Given this list of marker genes P2RX7, UBE2N, NLRP1, N, UBE2V1, PSTPIP1, RIPK2, TRAF6, HMOX1, TAB2, BCL2L1, MEFV, fljB, PANX1, UBB, MAP2K6, UBC, CASP9, BIRC3, TAB3, TXN (NCBI Gene Id 7295), RELA, CHUK, CASP4, RPS27A, hly, AIM2, MAPK11, CARD9, TXNIP, IRAK2, MAP3K7, NFKB1, ITCH, prgJ, NFKB2, NLRC4, CASP8, TAB1, MAPK14, NOD2 (nucleotide binding oligomerization domain containing 2), AAMP, HSP90AB1, NOD1, CASP1, IRAK1, IKBKG, TNFAIP3, NLRP3, IKBKB, APP, BCL2, SUGT1, PYCARD, fliC, MAPK13, BIRC2, UBA52, MAPK12, CASP2, CYLD, here is a description of the gene set: part of: Innate Immune System The innate immune system is the first line of defense against invading microorganisms, a broad specificity response characterized by the recruitment and activation of phagocytes and the release of anti-bacterial peptides. The receptors involved recognize conserved molecules present in microbes called pathogen-associated molecular patterns (PAMPs), and/or molecules that are produced as a result of tissue injury, the damage associated molecular pattern molecules (DAMPs). PAMPs are essential to the pathogen and therefore unlikely to vary. Examples are lipopolysaccharide (LPS), peptidoglycans (PGNs) and viral RNA. DAMPs include intracellular proteins, such as heat-shock proteins and extracellular matrix proteins released by tissue injury, such as hyaluronan fragments. Non-protein DAMPs include ATP, uric acid, heparin sulfate and dsDNA. The receptors for these factors are referred to collectively as pathogen- or pattern-recognition receptors (PRRs). The best studied of these are the membrane-associated Toll-like receptor family. Less well studied but more numerous are the intracellular nucleotide-binding domain, leucine rich repeat containing receptors (NLRs) also called nucleotide binding oligomerization domain (NOD)-like receptors, a family with over 20 members in humans and over 30 in mice. These recognise PAMPs/DAMPs from phagocytosed microorganisms or from intracellular infections. Some NLRs are involved in process unrelated to pathogen detection such as tissue homeostasis, apoptosis, graft-versus-host disease and early development (Kufer & Sansonetti 2011). <br><br><br>Structurally NLRs can be subdivided into the caspase-recruitment domain (CARD)-containing NLRCs (NODs) and the pyrin domain (PYD)-containing NLRPs (NALPs), plus outliers including ice protease (caspase-1) activating factor (IPAF) (Martinon & Tschopp, 2005). In practical terms, NLRs can be divided into the relatively well characterized NOD1/2 which signal via RIP2 primarily to NFkappaB, and the remainder, some of which participate in macromolecular structures called Inflammasomes that activate caspases. Mutations in several members of the NLR protein family have been linked to inflammatory diseases, suggesting these molecules play important roles in maintaining host-pathogen interactions and inflammatory responses.<br><br><br>Most NLRs have a tripartite structure consisting of a variable amino-terminal domain, a central nucleotide-binding oligomerization domain (NOD or NACHT) that is believed to mediate the formation of self oligomers, and a carboxy-terminal leucine-rich repeat (LRR) that detects PAMPs/DAMPs. In most cases the amino-terminal domain includes protein-interaction modules, such as CARD or PYD, some harbour baculovirus inhibitor repeat (BIR) or other domains. For most characterised NLRs these domains have been attributed to downstream signaling<br><br>Under resting conditions, NLRs are thought to be present in an autorepressed form, with the LRR folded back onto the NACHT domain preventing oligomerization. Accessory proteins may help maintain the inactive state. PAMP/DAMP exposure is thought to triggers conformational changes that expose the NACHT domain enabling oligomerization and recruitment of effectors, though it should be noted that due to the lack of availability of structural data, the mechanistic details of NLR activation remain largely elusive.<br><br>New terminology for NOD-like receptors was adopted by the Human Genome Organization (HUGO) in 2008 to standardize the nomenclature of NLRs. The acronym NLR, once standing for NOD-like receptor, now is an abbreviation of 'nucleotide-binding domain, leucine-rich repeat containing' protein. The term NOD-like receptor is officially outdated and replaced by NLRC where the C refers to the CARD domain. However the official gene symbols for NOD1 and NOD2 still contain NOD and this general term is still widely used. Reactome Pathway: Nucleotide-binding domain, leucine rich repeat containing receptor (NLR) signaling pathways studied in species Homo sapiens